The following is a description of a gene set: Mouse Gene Set: GOMF_TFIID_CLASS_TRANSCRIPTION_FACTOR_COMPLEX_BINDING species: Mus musculus Binding to a general RNA polymerase II transcription factor belonging to the TFIID complex, one of the factors involved in formation of the preinitiation complex (PIC) by RNA polymerase II., and this is the list of marker genes: Ruvbl1, Fbl, Ercc4, Ercc1, Ruvbl2, Trp53, Edf1, Nop58, Ahr, Znhit6